Given this list of marker genes METAP2, E2F8, FANCI, CKS2, PCLAF, DUT, RACGAP1, SMC4 (structural maintenance of chromosomes 4), CCNB2, DTYMK, ZWINT, TTK, HAT1, GAR1, VRK1, TOP2A, NDC80, MSH2, CDK1 (NCBI Gene Id 983), KIF18B, FEN1, HMMR, NASP (nuclear autoantigenic sperm protein), GINS1, FOXM1, SHCBP1, HMGB2, DTL, RAD51AP1, DKC1, MCM3, COPS3, DLGAP5, PRC1, POLE2, NUSAP1, MCM2, RFC4, HNRNPAB, CENPF (NCBI Gene Id 51468), MCM4, DHFR, RRM1, CCNA2, KIF11, SNRPD1 (NCBI Gene Id 6632), PCNA, PCCB, GMNN, GINS2, DNAJC9 (DnaJ heat shock protein family (Hsp40) member C9), MCM5, PLK4, TYMS, MCM7, RFC5, here is a description of the gene set: studied in species Homo sapiens Human Gene Set: GNF2_FEN1 Neighborhood of FEN1 flap structure-specific endonuclease 1 in the GNF2 expression compendium Neighborhood of FEN1